The following is a description of a gene set: studied in species Homo sapiens Human Gene Set: WP_NONGENOMIC_ACTIONS_OF_125DIHYDROXYVITAMIN_D3 Non-genomic actions of 1,25-dihydroxyvitamin D3, and this is the list of marker genes: RXRB, PRKCQ, DEFB4A, NRAS, CAMK2A, TLR2, PLCB2, STAT1, PLCG2, PRKCB, PRKCZ, IFNGR1, PLCB4, PRKCA, SP3, RXRG, MAPK12 (mitogen-activated protein kinase 12), CYP24A1, PLCD1 (phospholipase C delta 1), OAS2, RXRA, IKBKB, MAPK8, IFNA2, CXCL8, SP1, MAPK11, ETS1, PRKCG, KRAS, PRKCE, PLCB3, IFNG, NFKB1, NFKB2, DEFB4B, PRKCD, MAPK13, MAPK14, JAK1, HRAS, TNFRSF1A, MAPK3, NOD2, MAPK9, IFI44L (NCBI Gene Id 10964), IL6, CYP27B1, CAMK2G, CD40LG, ISG15, CD40, TLR4, CAV1 (caveolin 1), IFNAR2, TYK2, TLR8, CAMK2D, MAPK7, MAPK1, CAMK2B, PLCE1, PRKCH, CCL2, CAMP, RSAD2, STAT2, IFI27L2, RELB, MED1, PLCB1, VDR, TNF, JUN, IFNGR2